Given this list of marker genes Trim12a, Gm5796 (predicted gene 5796), Bmp4, Slc25a17, Ebpl, Sort1, Popdc2, Alkal1, Ifi44, Notch3, Cxcl12 (C-X-C motif chemokine ligand 12), Rarb, Pdgfb, Aldh1a3, Tgm2, Vmn2r43, Csprs, Nrk, Vmn1r93, Mmp2, Itga3, Ankrd44, Gm3636, Gm2012, 2200002D01Rik, Vmn1r180, Palmd, Spon2, Fxyd6, Adamts5, Sytl2, Dner, Ankrd1, ENSMUSG00000123629, Tnnc1, Gm10784 (NCBI Gene Id 625081), Slc16a4, Dhrs3, Il2rg, Or13a24 (olfactory receptor family 13 subfamily A member 24), Fbxl7, Speer4d, Zfp87, Myo7a, Speer4b (NCBI Gene Id 73526), Igfbp2, Col11a1, Foxd1 (forkhead box D1), Gdf15 (NCBI Gene Id 23886), Ccl25, Timm8b, Rflnb, Gatm, Igf2r, 4930469B13Rik, Fam177a, Speer4a1, 4933409K07Rik, Mest, Pierce1, Vmn2r-ps105, Gm10375, Bloc1s3, Esd, Rabl2, Klhl30, Slamf9, Mpeg1, Myh11, Stom, Epha4, Pde5a, Cers4, Foxf1, C1qb, Tceal1, Dmpk, Dcaf12l1, Fzd6, Ctss, Lama5, Cd200, Sult4a1, Ccng2, Hoxc6, C1qa, D830030K20Rik (RIKEN cDNA D830030K20 gene), Sfn, Gadd45a, Gpx3, 4930555G01Rik, Adamts10, C1qtnf12, Hipk2, Ccl17, Nes, Fas, Pitx2, Tmem223, Kif21b, Ablim1, Lpcat2, Plekhh2, Slc7a7, Gm5925, Rgs5, Susd2, Gm7609, Gm14819, C1qc, Gm5891, Mup2, Alx1, Sfi1, Scube3, Fam210b, Or6c70, Pgpep1, Spsb1, Lyz2, Aldh1a1, Cybb, Olfml2b, Serping1, Btbd35f1, Gm10058, Ppp1r14a, Epha7, Ldb2, Prss35, Gm5431, Gdpd5, Tmtc1, Irgm1, Cmbl, Epcip, Tmem88, Gm57857, Dusp6, Apoe, Hoxa6, Vmn2r37, Laptm5, Hoxb9, Ctsc, Aif1l, 1810037I17Rik, Spin2-ps1, Pappa2, Ccdc68, Psme2, Atp10d, Myl12b, Slfn2, Gm9732, Ddah2, Ssbp2, Vmn2r29, Vnn1, Nupr1, Gm10128, Plekha2, Gm10413 (predicted gene 10413), Klhl24, Hmcn1, Mcee (methylmalonyl CoA epimerase), Eng, Kcnmb1, Fjx1, Gm5622, 1700054O19Rik, Cd52, Gm10408, Jpt2, Fibin (fin bud initiation factor homolog (zebrafish)), Potefam3e, Ctsh, Foxc1 (forkhead box C1), Plod2, Nfkbie, Gm3264, Mogat2, Ntn4, Gm5458, Aga, Cdh10, Igf1, Renbp, B930095G15Rik, Vmn1r178, Dapk1, Gm6541 (NCBI Gene Id 631185), Dsp, C3ar1, Gm13498, Gm5168, Rplp1, Duxf3, Hoxb6, Dgkk, Vmn1r183, Speer4e1, Txnip, Abhd1, Morrbid, Mup-ps2, Sncg, Itpripl2, Styxl2, Map3k7cl, Sat1, Emcn, Vmn1r148, Myom1, Hoxa5, Gm3029, Ptp4a3, Krtap5-2, Adgrf5, Tnnt2, Ier3ip1, Pcgf5 (polycomb group ring finger 5), Cdkl3, Galnt11, here is a description of the gene set: Genes up-regulated in MEF cells (embryonic fibroblast) with ELAVL1 knocked out. HuR is an RNA-binding protein implicated in a diverse array of pathophysiological processes due to its effects on the posttranscriptional regulation of AU- and U-rich mRNAs. Here we reveal HuR's requirement in embryonic development through its genetic ablation. Obligatory HuR-null embryos exhibited a stage retardation phenotype and failed to survive beyond midgestation. By means of conditional transgenesis, we restricted HuR's mutation in either embryonic or endothelial compartments to demonstrate that embryonic lethality is consequent to defects in extraembryonic placenta. HuR's absence impaired the invagination of allantoic capillaries into the chorionic trophoblast layer and the differentiation of syncytiotrophoblast cells that control the morphogenesis and vascularization of the placental labyrinth and fetal support. HuR-null embryos rescued from these placental defects proceeded to subsequent developmental stages but displayed defects in skeletal ossification, fusions in limb elements, and asplenia. By coupling gene expression measurements, data meta-analysis, and HuR-RNA association assays, we identified transcription and growth factor mRNAs controlled by HuR, primarily at the posttranscriptional level, to guide morphogenesis, specification, and patterning. Collectively, our data demonstrate the dominant role of HuR in organizing gene expression programs guiding placental labyrinth morphogenesis, skeletal specification patterns, and splenic ontogeny. from publication Katsanou V, Milatos S, Yiakouvaki A, Sgantzis N, Kotsoni A, Alexiou M, Harokopos V, Aidinis V, Hemberger M, Kontoyiannis DL (PMID 19307312) species: Mus musculus Mouse Gene Set: KATSANOU_ELAVL1_TARGETS_UP